Given this list of marker genes SLC13A5, SLC16A1, SLC13A3, SLC13A2, SLC25A10, here is a description of the gene set: The process in which succinate is transported across a membrane. studied in species Homo sapiens Human Gene Set: GOBP_SUCCINATE_TRANSMEMBRANE_TRANSPORT